The following is a description of a gene set: species: Homo sapiens Binding to an AP-2 adaptor complex. The AP-2 adaptor complex is a heterotetrameric AP-type membrane coat adaptor complex that consists of alpha, beta2, mu2 and sigma2 subunits and links clathrin to the membrane surface of a vesicle. In at least humans, the AP-2 complex can be heterogeneric due to the existence of multiple subunit isoforms encoded by different alpha genes (alphaA and alphaC). Human Gene Set: GOMF_AP_2_ADAPTOR_COMPLEX_BINDING, and this is the list of marker genes: HIP1, LMBRD1, SIDT2, AAK1, FCHO1, RAB38, LDLRAP1, TBC1D5, BMP2K, RAB32